The following is a description of a gene set: species: Homo sapiens Human Gene Set: HNF3_Q6 Genes having at least one occurrence of the motif NWRARYAAAYANN in the regions spanning 4 kb centered on their transcription starting sites. This matches the FOXA1 transcription factor binding site V$HNF3_Q6 (v7.4 TRANSFAC)., and this is the list of marker genes: TIMP4, ITPKB, SARM1, GPRIN3, H2AZ2, SLC13A1, PRDM1, ADTRP, TJP1, ATXN7L1, NR4A1, NAV3, BMP5, PIK3C2A, NSG2, HAND2 (NCBI Gene Id 9464), DRD3, ALDH9A1, TSHZ2, CDH10, CCN1, CILK1, CELF4 (CUGBP Elav-like family member 4), PATL1, PABIR1, LHX9, ATOH1, LCP2, SLITRK6, NEUROD2, NRAS, CLDN8, NOVA1, DUSP6, ZBTB37, METTL18, PURA, PRDX5, PCDH17, IRS4, ARHGAP30, CHCHD7, ATXN7L2, GNAZ, PACSIN3, TMCC1, HOXB3, FOXN1, SLC10A7, XPO4, GCNT2, LUC7L, TNMD, GATA6, KRT222, MACROH2A1, GFRA1, PTGR3, CLDN2, DNAJC22, FIRRM, TMEM185A, LMO3, NFIA, MEF2C, FEZF2, SOSTDC1, ING3, SRGN, NECTIN1, ZIC5, UHRF2, TEAD1, VAX1, TLE3, FOXD3, FABP4, TBXAS1, MSTN, IL25, ABI1, KLF7, LINC00314, BCL11B, NR4A3, CALD1, SYN3, CYP26B1, CDKN1A, HOXA11, ARHGEF2, CHRDL1, KRT17, ATP2A2, PRR34, ASCL1, SLC39A8, KCNK4, ITGA3, SMARCA2, GNAO1, CYP7A1, TFDP2, ADAMTS14, BAMBI, IRX5, LINC00474, TMEM88, KCNQ5, VTN, PALMD, TYRO3, FOSB, MAP3K13, CADM2, MAB21L3, SLC44A1, COL13A1 (collagen type XIII alpha 1 chain), GRIK2, HIVEP3, ACACA, IL16, GTF2A1 (general transcription factor IIA subunit 1), NMNAT2, MYL1, AHI1, POGZ, GABARAPL1, DMD, PDCD4, PTPRG, HOXA10, FGF13, FLRT3, ZHX2, STOML2, LINC01101, HESX1 (NCBI Gene Id 8820), LGI1, BRIP1, KCTD15, OTP, ANGPTL1, NR1D1, AFF3, NRG1, OTX2, DEPDC7, SLIT3, RTL9, EGR2, ATP1B4, HAPLN1, NPY (neuropeptide Y), PHEX, GOLGA1, TGFB3, CRH, ADGRB3, RBP3, LRRTM3, EBF2, NEBL, TNR, SNX25, RREB1, SMPX, C8B, SCUBE3, PLAG1, MIDEAS, TSHZ3, NKD1 (NKD inhibitor of WNT signaling pathway 1), ATOH8, TRMT112, REEP4, DNASE2B, SKIDA1, FOXA2, SPIB, TWIST1, NDST2, PPP1CB, ERRFI1, ID1, FGF9, ZNF436, SNAP25, TOB1, FBXO11, BDH1, SGK1